The following is a description of a gene set: studied in species Homo sapiens Any process that modulates the rate, frequency or extent of plasminogen activation. Plasminogen activation is the process in which plasminogen is processed to plasmin. Human Gene Set: GOBP_REGULATION_OF_PLASMINOGEN_ACTIVATION, and this is the list of marker genes: PLAT (NCBI Gene Id 5327), HPN, MELTF, SERPINE1, S100A10, CTSZ, SERPINF2, CLEC3B, THBS1, ANXA2, ENO1, PLGRKT, PLAU, RUNX1, SERPINE2, F12, PLAUR